The following is a description of a gene set: from publication Chen Y, Wang X (PMID 31504780) Mouse Gene Set: MIR_7057_3P species: Mus musculus Genes predicted to be targets of miRBase v22 microRNA mmu_miR_7057_3p in miRDB v6.0 with MirTarget v4 prediction scores > 80 (high confidence targets)., and this is the list of marker genes: Prkg1, Cntln, Arhgap6, Sbf2, Esyt2, Trim59, Edil3, Exoc5, Fyttd1, Tnfrsf11b, Xiap (X-linked inhibitor of apoptosis), Pdk4, Aebp2, Mtmr7, Dpp8, Zmym2, Spmip4, Htr2c, Ap1s3, Fsd1l, Ctps2, Ccdc47, Bank1, Slc1a3, Acvr1, Ctla2b, Kmt5b, Cttnbp2nl, Scai, Prl5a1, Arf6, Nampt, Kcnma1, Kcnc2, Col4a1, Ubn2, Tfam, Strn, Pik3c2a, Cpeb2, Trappc13, Apbb2, Rspo1, Plag1, Fbxl20, Adrb3, Lsamp, Slc7a11 (solute carrier family 7 (cationic amino acid transporter, y+ system), member 11), Rnd3, Mrpl32, Bccip, Fem1c, Rnpc3, Fignl1, Ttll7, Mtfr2 (mitochondrial fission regulator 2), Sanbr (SANT and BTB domain regulator of CSR), Or51m1, F2r, Nabp1, Dazap2, Apob, Cfap20dc, Cct6a, Ppp1r15b, Rap2c, Nat3, Rheb, Snap91, Tigd4, Ptprm, Usp31, Cir1, Zbtb25, Decr1, Ppp1cb, Lrfn5, Lats2, Cfap52, Clint1, Cks2, Picalm, Sox17, Nrarp, Ccar1, Cbr3, Fras1 (Fraser extracellular matrix complex subunit 1), Spock3 (NCBI Gene Id 72902), Phip, Ssbp1, Nrk, Nsd3, Rps6, Tmem33, Hook3, Yipf5, Plce1, Mapkap1, Cnpy1, Or51e2, Fmr1nb, Ret, Fcho2, F2, Psg17, Zrsr2, Tnpo1, Ccne2, Lrrc2, Dlg2, Pign, Mtap, Arpp21, Smad2, Arl6ip6, Tead1, Trpc5os, Rab23 (RAB23, member RAS oncogene family), Hus1, Gabra4, Bmpr2, Zfp551, Dpm1, Col4a5 (NCBI Gene Id 12830), Adamts19, Sirt2, Ammecr1, Pelo, Ccdc77, Vwc2, Six4 (sine oculis-related homeobox 4), Trim30b, Eloc, Ptrhd1, Asf1a, Pnp, Pnrc1, Zfp800, Jag1, Gsap, Tmem245, Gmcl1, Slc25a32, Rimklb, Pcdh11x, Dgkg, Nrg3, Wdr43, Airim, Mmp20, Hnrnpr, Corin, Fgfr2, Bag5, Grk4, Serpinb6b, Zfp459